Given this list of marker genes IGF2, PTRH2, HNF1A, GLIS3, KLF11, EFL1, SLC29A3, NEUROD1, INS, PDX1, BLK, ABCC8, GCK, APPL1, HNF1B, DNAJC21, KCNQ1, SBDS, RARB, STRA6, KCNJ11 (potassium inwardly rectifying channel subfamily J member 11), LHX1, CNOT1, PTF1A, KCNQ1OT1 (NCBI Gene Id 11111), RFX6, FOCAD, HNF4A, CEL, GATA6, PAX4, CDKN1C, STAT3, WNT7B, here is a description of the gene set: studied in species Homo sapiens A deviation from the normal size of the pancreas. Abnormal pancreas size Human Gene Set: HP_ABNORMAL_PANCREAS_SIZE